Given this list of marker genes Desi2, Acot2, Acnat1, Acot13, Acot12, Acot5, Acnat2, Acot8, Acot3 (acyl-CoA thioesterase 3), Desi1, Acot4, Acot6, Hnf4a, Them7, Hibch, Acsbg2, Acot9, Mblac2, Baat, Acot1, Cln5, Acot10, Abcd2, Acaa2, Acot11, Acot7, Ppt1, Pla2g6, Abcd1, Them5, Abcd3, Them4, here is a description of the gene set: studied in species Mus musculus Catalysis of the reaction: an acyl-CoA + H2O = a carboxylate + CoA + H+. Mouse Gene Set: GOMF_ACYL_COA_HYDROLASE_ACTIVITY